Given this list of marker genes CCDC115, CTTN, ATP6V0E1, PVR, ADAMTS6, DNASE1L2, SEPTIN7, BLOC1S4, TMED2, GPN2, PSMA6, BPIFB2, ACP1, RLIM, CASD1, CYP2A6, UBXN4, USO1, SPSB3, MAP2K3, KRT20, TGFA, TXNL1, RAB1A, BUB1, AP3S1, CRK, PCSK9, GOLGA7, USP14, TTC1, RRAGB, PLS3, H2AZ1, PCLAF, DDX5, PDCD10, FTSJ3, SH2D2A, PPP1R15A, here is a description of the gene set: Our recent study identified 2,261 dysregulated genes in the esophagi of rats that received a 1-week exposure to the carcinogen N-nitrosomethylbenzylamine (NMBA). We further reported that 1,323 of these genes were positively modulated to near-normal levels of expression in NMBA-treated animals that consumed dietary phenylethyl isothiocyanate (PEITC), a constituent of cruciferous vegetables. Herein, we report our results with companion animals that were fed a diet containing 5% freeze-dried black raspberries (BRB) instead of PEITC. We found that 462 of the 2,261 NMBA-dysregulated genes in rat esophagus were restored to near-normal levels of expression by BRB. Further, we have identified 53 NMBA-dysregulated genes that are positively modulated by both PEITC and BRB. These 53 common genes include genes involved in phase I and II metabolism, oxidative damage, and oncogenes and tumor suppressor genes that regulate apoptosis, cell cycling, and angiogenesis. Because both PEITC and BRB maintain near-normal levels of expression of these genes, their dysregulation during the early phase of NMBA-induced esophageal cancer may be especially important in the genesis of the disease. Genes up-regulated in esophagus by the carcinogen NMBA and brought back to normal by a diet with PEITC or black raspberries. from publication Stoner GD, Dombkowski AA, Reen RK, Cukovic D, Salagrama S, Wang LS, Lechner JF (PMID 18676871) Human Gene Set: STONER_ESOPHAGEAL_CARCINOGENESIS_UP studied in species Rattus norvegicus